Given this list of marker genes GNB3, H4C5, AHDC1, POGZ, COL11A2, OFD1, here is a description of the gene set: Mild myopia studied in species Homo sapiens A mild form of myopia with up to -3.00 diopters. Human Gene Set: HP_MILD_MYOPIA